Given this list of marker genes CYP2C8, GPX4, CYP3A4, EPHX2, PTGS2, CYP2C9, LTC4S, ALOX5, LTA4H, ALOX15, HPGD, ALOX12, GSTM4, CYP1A2, CYP1A1, CYP2E1, CYP2D6, here is a description of the gene set: Reactome Pathway: Biosynthesis of DHA-derived SPMs species: Homo sapiens part of: Biosynthesis of specialized proresolving mediators (SPMs) Docosahexaenoic acid (DHA), a major ω-3 polyunsaturated fatty acid (PUFA) found in fish oil is the source of D-series resolvins (RvDs), one of the specialized proresolving mediators (SPMs) that show potent anti-inflammatory and pro-resolving actions. The biosynthesis of RvDs occurs mainly during the process of inflammation when endothelial cells interact with leukocytes. Dietary DHA circulates in plasma or is present in cellular membranes as it can easily integrate into membranes. On injury or infection, DHA moves with edema into the tissue sites of acute inflammation where it is converted to exudate RvDs to interact with local immune cells. The initial transformation of DHA by aspirin-acetylated cyclooxygenase-2 or cyclooxygenase-mediated catalysis can produce stereospecific D-resolvins (18(R)- or 18(S)-RvDs respectively). Combinations of oxidation, reduction and hydrolysis reactions determine the type of D-resolvin formed (RvD1-6).